Given this list of marker genes PYGO1, GJA3 (gap junction protein alpha 3), PRKAA2, PRKAB2, FMO5, PYGO2, GJA1, PRKAG1, NBPF12, TJP1, PRKAG3, GJA5, LINC00624, CTNNB1, PRKAG2, PRKAB1, RNVU1-8, GJA8, CHD1L, TJP2, TJP3, ACP6, BCL9, PRKAA1, OCLN, AMELX, KIRREL1, F11R, AFDN, here is a description of the gene set: Human Gene Set: WP_1Q211_COPY_NUMBER_VARIATION_SYNDROME 1q21.1 copy number variation syndrome studied in species Homo sapiens